Given this list of marker genes MAPRE2 (microtubule associated protein RP/EB family member 2), HLA-DQB1, HAND1, MTCP1, FGF9, SNTB2, KRTAP4-6, here is a description of the gene set: Genes predicted to be targets of miRBase v22 microRNA hsa-miR-1273c in miRDB v6.0 with MirTarget v4 prediction scores > 80 (high confidence targets). studied in species Homo sapiens from publication Chen Y, Wang X (PMID 31504780) Human Gene Set: MIR1273C